The following is a description of a gene set: species: Mus musculus Mouse Gene Set: chr10C2, and this is the list of marker genes: Elk3 (NCBI Gene Id 319474), Gm33336, Gm48425, Amdhd1, Ikbip (NCBI Gene Id 97672), Cep83os, Nedd1, Mir331, Cfap54, Gm47708, Gm31822, Eea1, Mir1251, Gm3619, Ndufa12, Mir135a-2, Gm8580, Gm18043, Actr6, Mir1931, Tmcc3, Gm32468 (predicted gene, 32468), Gm20757, 5730420D15Rik, Gm26122, Tmpo, Gm24241, Gm31592, Cradd, 4930471D02Rik, Rmst, Atg5lrt, Mir7211, Gm5780 (predicted gene 5780), Cep83 (NCBI Gene Id 77048), Nr2c1, Mir7688, Socs2, Gm49817, Ube2n, Hal, 4930534H03Rik, Gm8512, Nudt4, Gm18391, 4933408J17Rik, Snrpf, Metap2, Fgd6, Gm25390, Plxnc1, Slc17a8 (NCBI Gene Id 216227), Gm33543, Usp44, Gas2l3, Cdk17, Gm48191, Bltp3b, Mir3058, Gm24119, Gm4792, Anks1b, Gm32688, 4732465J04Rik, Gm18670, Anapc15-ps, Gm33091, 4930401A07Rik, Slc25a3, 1500026H17Rik, Ntn4, Nr1h4, Apaf1, Mrpl42, Vezt, Scyl2, Gm3571, Gm3523, Gm48658, Gm24433, Gm25884, Ccdc38, Gm18705, 2310039L15Rik, 1110019B22Rik, Gm15915 (NCBI Gene Id 100504069), Ano4, Gm4800, Lta4h